Given this list of marker genes STXBP3, TAP1, SNX9, RAD23B, SCARB2, TBX21, PLP2, MYO1C, PLEKHA2, CSF1, MAN1A1, TMEM183A, IFITM3, ZDHHC16, SEPTIN2, IL10, IRGM, NCF1, MYL12B, OAS1, GNA11, CDKN1A, TMIE, CCDC28B, SMURF2, CD47, XBP1, PNPLA2, ARRDC4, FMR1, CACNB3, TSPYL4, IDH2, FLT3LG, RAB1A, KRT80, JPT2, ARL5A, RPAP3, RAB14, TBC1D2B, CRK, CGGBP1, DYRK2, G3BP2 (G3BP stress granule assembly factor 2), IFNG, VIM, GZMB, ADAM9, HLA-DMA, GPLD1, SCOC, ADGRE5, PXN, SUSD2, PDLIM4, SERPINB9, MAP3K5, FNDC3A, ISG20, LRRC8A, SYTL3, PSMB8, HM13, SYNE2, ZBTB18, PIK3C2A, CD40, XPO1, SLC19A2, EHD1, ABR, PTPN1, ITGB2, TBCD, UBE2L6, H2BC5, DCUN1D3, SH3GLB1, INPP5A, P2RY14, MOSMO, NFE2L2, ICOSLG, CTSC, UBALD2, RRAS, TGFBR2, ANKRD17, SH3RF2, PPP1CC, PARP12, MGAT4A, C3orf18, ATG4C, ZNF367, TRIM34, HIPK2, ERN1, PCMT1, NAMPT, KCNAB3, LPCAT3, TRAFD1, CHST12, TMEM176A, ARPC1A, VAMP3, SEL1L, CTNNB1, ZBP1, TAPBPL, ID2, PSME2, PSME1, GPR18, ADPRH (ADP-ribosylarginine hydrolase), SNX2, CFL2, TWF1, TUBE1, UBA7, LPIN2, ICAM1, RUNX3, SKP2, VPS13A, ESM1, EIF2B5, RAP1GDS1, OLFM3 (olfactomedin 3), SEMA7A, WFS1, STX12, NIN, ABCB9, ERMP1, SGK1, NEB, PLAAT3, P2RX4, ABHD16A, MARK3, PLAC8, ZHX1, SPAST, NRBP1, TMEM176B, LPP, ARL4A, CCR7, MNS1 (meiosis specific nuclear structural 1), RBM43, PLCB3, UBE2J1, DAGLA, DTX3L, HLA-C, PCGF3 (polycomb group ring finger 3), FEM1B, AGPAT4, GPCPD1, MAN2A1, PSMB10, ACBD5, ARAP2, LDLRAP1, ITPK1, NABP1 (nucleic acid binding protein 1), NRARP, TPST2, HIF1AN, RFX5, SOCS3, RIGI, ZNF652, IRF1, BRWD3, FAP, CYGB, SLC35B1, LATS1, DCUN1D4, RAB12 (NCBI Gene Id 201475), CTBS, GBP2, STAU1 (staufen double-stranded RNA binding protein 1), KAT2B, CHD7, GRAMD2B, CYBA, SUPT16H, CRTAP, VPS54, STAG1, B4GALT4 (NCBI Gene Id 8702), SLC8B1, ETNK1, TLR2, CLIC1, here is a description of the gene set: Human Gene Set: GSE18893_TCONV_VS_TREG_2H_CULTURE_DN from publication Nagar M, Jacob-Hirsch J, Vernitsky H, Berkun Y, Ben-Horin S, Amariglio N, Bank I, Kloog Y, Rechavi G, Goldstein I (PMID 20181891) Genes down-regulated in lymphocytes treated with medium for 2h: T conv versus T reg cells. Here we show that tumor necrosis factor (TNF) induced in human T-regulatory cells (Treg), as compared to conventional T cells (Tcon), a transcription program highly enriched for typical NF-κB target genes, such as: the cytokines LTA and TNF; the TNF-receptor super family members FAS, 4-1BB and OX-40; various anti-apoptotic genes; and other important immune-response genes. As an initial approach to examine the cellular program induced by TNF in Tregs versus Tcon cells, we employed microarray gene expression analysis at 2 and 24 hrs following TNF treatment. species: Homo sapiens